The following is a description of a gene set: species: Homo sapiens Human Gene Set: HP_DILATION_OF_VIRCHOW_ROBIN_SPACES Dilation of Virchow-Robin spaces Increased dimensions of the Virchow-Robin spaces (also known as perivascular spaces), which surround the walls of vessels as they course from the subarachnoid space through the brain parenchyma. Perivascular spaces are commonly microscopic, and not visible on conventional neuroimaging. This term refers to an increase of size of these spaces such that they are visible on neuroimaging (usually magnetic resonance imaging). The dilatations are regular cavities that always contain a patent artery., and this is the list of marker genes: PTEN, DCX, ZFX, GLUL, KMT5B, HTRA1, H3-3A, RPL10, ZSWIM6, CLCN3, ALG2, ASXL2, NGLY1, RIN2, H4C9, SIAH1, ODC1, PLXNA1, COL4A1, PAFAH1B1